Given this list of marker genes C1QTNF5 (NCBI Gene Id 26141), COL18A1, POMGNT1, HGSNAT, TUB, KLHL7, DPAGT1, MMP19, B3GALT6, TULP1 (NCBI Gene Id 7287), CNGA3, SCAPER, TUBB4B, ZNF408, COL4A1, here is a description of the gene set: A pale yellow discoloration of the entire optic disc. Human Gene Set: HP_DIFFUSE_OPTIC_DISC_PALLOR species: Homo sapiens Diffuse optic disc pallor